Given this list of marker genes NDUFA11, SEC31A, ELK3, GRK2, COL5A1, DNAJB2, PARP16, SEC11A, PPP2R1A, CDC6, FTH1, MRM1 (mitochondrial rRNA methyltransferase 1), ZC3H18, TEX10, NUCKS1, C1QTNF4, ARHGDIB, UBA2, CCT8, PTPN11, HERC2, HP, SUCO, OCEL1, R3HDM1, NOL12, EIF3L, GMFG (glia maturation factor gamma), PIK3C2A, EIF3B, ADORA2B, MKI67, USP34, HSD17B12, SRFBP1, UBL5, LTV1, PADI1, BRCA1, CCT3, ATP1A1, PPP1R18, RAB11A, DLG1, KLHDC4, FNTA, SNAPC2, PRKRIP1, SIRT7, TMED7 (NCBI Gene Id 51014), CKS2, PRMT3, TIMM8A, TMEM203, AKR1B15, SF3B3, STT3A, NELFB, RNF5, GNPDA1, HBS1L, SYNPO2, H2AJ, DIABLO, NAPG, SMN1, ACAD9, DNAJC2, RRP36, RIC8A, KLHL21, IFNGR1, DGKZ, SDHC, SENP2, NUFIP1, TRAF3IP2, DDT, LRRC20, MRRF, UBAP1, CLMP, RMND5A, TRAPPC4, PSMA1, ELOC, SHC1, HSPA4 (heat shock protein family A (Hsp70) member 4), LPIN1, DHRS7B, ACLY, ATP6V1A, PIM3, SLC14A1, GSTA5, PTGER4, SFXN4, GALNT6, KRTAP8-1, CTDP1, SLC66A2, RTN4R, CRABP1, CD38, TMEM184C, PAFAH1B2, ABHD5, CLPP, MRPL57, DEGS1, CCT7, CYFIP2, RETREG1, BTF3L4, CCDC43, DARS1, DRG1, KCNK10, EIF4A1, OSGIN1, EMC7, SLC39A9, MEF2D, IRF3, PUS7, POLR2K, HVCN1, FERMT3, SDHD, USP9X, COA3, ZFYVE16, PPP1R14B, PPARGC1A (NCBI Gene Id 10891), PURB, AIFM1, UFM1, IL23A, POU2F2, SKP2, PAFAH2, ADCY9, STK40, ST3GAL1, CLSTN3, SNHG6, CCT4, TMEM120B, CCDC115, LSM2, FAH, TMEM165, XYLT2, LYAR, FCER1G, PIGM, UQCRQ, LARP7, MRPS18A, TUSC2, MRPS21, TSR2, PUM3, SLC22A5, ARMT1, PSMD4, ARHGAP35, ACRBP, SDC1, NMD3, TXNL4A, RHOT1, PLA2G6, UTP20, EIF2S3, LARS1, TBPL1, PFKL, HECTD1, ELAVL1 (NCBI Gene Id 1994), RAB40C, MAPRE2, EIF2B5, QPCTL (NCBI Gene Id 54814), CHADL, STAC, PHYKPL, MAGI1, EIF4H, HTT, TP53RK, NCBP1, PWP2, NCF2, ARHGAP1 (Rho GTPase activating protein 1), MYADM, KICS2, BIRC5, TRAPPC2, here is a description of the gene set: Human Gene Set: GSE17721_POLYIC_VS_PAM3CSK4_6H_BMDC_DN mouse primary BMDCs were stimulated with tlr ligands and gene expression changes were profiled on Affymetrix arrays Genes down-regulated in comparison of dendritic cells (DC) stimulated with poly(I:C) (TLR3 agonist) at 6 h versus DC cells stimulated with Pam3Csk4 (TLR1/2 agonist) at 6 h. species: Homo sapiens from publication Amit I, Garber M, Chevrier N, Leite AP, Donner Y, Eisenhaure T, Guttman M, Grenier JK, Li W, Zuk O, Schubert LA, Birditt B, Shay T, Goren A, Zhang X, Smith Z, Deering R, McDonald RC, Cabili M, Bernstein BE, Rinn JL, Meissner A, Root DE, Hacohen N, Regev A (PMID 19729616)